Given this list of marker genes Fos, Fosb, Uba52, Dusp1, Hspa1b, Junb, Jun, Klf6, Cxcr4, Tsc22d3, Klf2, Hspa1a, here is a description of the gene set: from publication Cui A, Huang T, Li S, Ma A, Pérez JL, Sander C, Keskin DB, Wu CJ, Fraenkel E, Hacohen N (PMID 38057668) studied in species Mus musculus Mouse Gene Set: CUI_T_CELL_GD_IL1RA_RESPONSE_DN Cytokines mediate cell-cell communication in the immune system and represent important therapeutic targets. A myriad of studies have highlighted their central role in immune function, yet we lack a global view of the cellular responses of each immune cell type to each cytokine. To address this gap, the authors created the Immune Dictionary, a compendium of single-cell transcriptomic profiles of more than 17 immune cell types in response to each of 86 cytokines (>1,400 cytokine-cell type combinations) in mouse lymph nodes in vivo. A cytokine-centric view of the dictionary revealed that most cytokines induce highly cell-type-specific responses. For example, the inflammatory cytokine interleukin-1β induces distinct gene programmes in almost every cell type. A cell-type-centric view of the dictionary identified more than 66 cytokine-driven cellular polarization states across immune cell types, including previously uncharacterized states such as an interleukin-18-induced polyfunctional natural killer cell state. Genes negatively differentially expressed in cell type: γδ T cell upon treatment with cytokine: IL-1Ra in mouse lymph nodes in vivo.